The following is a description of a gene set: species: Mus musculus Mouse Gene Set: GOBP_NEGATIVE_REGULATION_OF_ERYTHROCYTE_DIFFERENTIATION Any process that stops, prevents, or reduces the frequency, rate or extent of erythrocyte differentiation., and this is the list of marker genes: Hoxa5, Lmo2, Ypel4, Zfp36, Stat5a, Klf13, Mafb, Ldb1, Zfp36l1, Stat5b, Hspa9